The following is a description of a gene set: To understand the functional relationship between brain dendritic cells (brain DCs) and other myeloid cells, we compared the gene expression profile of m/chDCs to that of bone marrow monocytes, brain microglia and classical spleen CD8+ and CD8- DCs. In order to obtain enough brain DCs for mRNA extraction, we expanded brain DCs with in vivo Flt3L treatment before purification. species: Homo sapiens Genes up-regulated in brain microglia versus spleen CD8- dendritic cells. from publication Anandasabapathy N, Victora GD, Meredith M, Feder R, Dong B, Kluger C, Yao K, Dustin ML, Nussenzweig MC, Steinman RM, Liu K (PMID 21788405) Human Gene Set: GSE29949_MICROGLIA_BRAIN_VS_CD8_NEG_DC_SPLEEN_UP, and this is the list of marker genes: ASIP, CUL2, AKAP9, QKI (NCBI Gene Id 9444), EPHA1, LEP, KYNU, MX1, CFTR, NDRG2, CRIP1, NINL (ninein like), LSS, GPR45, MET, NCR1, RGS16, LMO2, F12, SLC34A1, EGR1, GALNT2, DOK1, ERF, SPINT3, ZNF165, ZNF529 (zinc finger protein 529), RWDD2A, ARF3, BASP1, EPYC, EVI5, UNC13B, APOBEC3G, UTP20, SERPINA5, ADH1B, SLC39A14 (NCBI Gene Id 23516), BMPR1A, FLNA, VPS13A, ARFIP1, GUCY1A1, CCL20, JCAD, MYO5A, FGG, CD79B, MTMR6, KCNN3, CNNM2, MMP7, EIF3A, LAPTM4B, SMAD9, KRT1, HRH1, EML3, STAC, KLRA1P, STARD3, CAPG, CROT, VSNL1, DIXDC1 (NCBI Gene Id 85458), PHKG2, TOMM34, ABCA1, CCL5, GPRC5B, TNFRSF1B, RFPL3S, BMERB1, MTMR2, SEMA3D, ZNF629, CPSF1, MMP20, HBE1, IGHV3OR16-13, DPH2, NT5E, RBPJ, ZNF510, BAZ1B (bromodomain adjacent to zinc finger domain 1B), HSPA2, CCL15, PGC, NPR2, ERCC2, CCNT1, ATP2B1, B3GALT5, LOXL2, RIMS3, ARL4A, SPRR1B, MMP13, PDGFRL, HPS1, EPB41L3, DGKB (NCBI Gene Id 1607), ZFP36L2, RUVBL1, CHUK, CSN1S1, CD83, MGST3, CPN2, IRF6, GRIN2B, PMPCA, EIF2B4, TRIP4, EDEM1, PALS2, POM121L1P, MZF1, LIFR, UPK1B, CELSR2, SPAM1, TNFSF12, KLHL25, ZNF37A, GADD45G, ISG15, TBL3, CA5A, FCGR3B, TATDN2, RNF103, ZNF688, ATP1A2, NUMB, LARP7, AHR, UGT2B15, UBA1, NEB, SYCP1, IL11, SELENOW, SV2A (synaptic vesicle glycoprotein 2A), ADAMTSL2, ANKRD12, POLR2F, SORT1, UPP1, VPS11, GCNT1, USP12 (NCBI Gene Id 219333), ATP2B2, MTCL1, CHN1, ST7, SLC25A17, MOCS3, ZNF208, SDC4, ANO3, GPR176, HMGA2, ULK2, LPL, NPTX1, SCN9A (NCBI Gene Id 93955), KLKB1, ECM2, ABCC10, CXCR3, SP4, FMO5, TOX3, PIR, HNF1B, TNFSF14, LGALS8, LGALS3, NR4A1, RAB22A, HMG20B, FRY, APOBEC3C, SKIL, SPTSSA, SGCG, LTB, HSD17B10, RPS21, CD200, MPZ (NCBI Gene Id 4359), CACNA1S, STON1, GABRE